The following is a description of a gene set: mouse primary BMDCs were stimulated with tlr ligands and gene expression changes were profiled on Affymetrix arrays Human Gene Set: GSE17721_12H_VS_24H_POLYIC_BMDC_DN species: Homo sapiens from publication Amit I, Garber M, Chevrier N, Leite AP, Donner Y, Eisenhaure T, Guttman M, Grenier JK, Li W, Zuk O, Schubert LA, Birditt B, Shay T, Goren A, Zhang X, Smith Z, Deering R, McDonald RC, Cabili M, Bernstein BE, Rinn JL, Meissner A, Root DE, Hacohen N, Regev A (PMID 19729616) Genes down-regulated in comparison of dendritic cells (DC) stimulated with poly(I:C) (TLR3 agonist) at 12 h versus those stimulated at 24 h., and this is the list of marker genes: SYNGR2, EIF3B, CD72, TP53INP1, C12orf57, NDUFC2, SS18L2, TMEM126A, POLR2A, OTULINL, SLC5A9, KLHDC4, PIP4P2, CD1D, TMEM161A, BRIX1, CYB5A, MS4A7, ENO3, B4GALT1, TRIM27, TCF12, ECD, PPT2, DNAJA3, CDCA3, NAA60, CTCF, CCT4, SLFN12, CSDE1, PEA15, ANAPC11, CLCC1, STK17B, GLI2, HINT3, HYOU1, CCT8 (NCBI Gene Id 9888), NCBP3, ITFG2, FOXK2, SNX15, RAC2, PTEN, WBP2, ENTREP3, ZMIZ2, NR2C1, NCBP1, SMC3, NSUN2, SDHD, DGKZ, TTLL1, UAP1L1, PTPN14, HEXIM1, DDX18, CSE1L, MAVS (NCBI Gene Id 78993), RCC1L, MORF4L1, PHF2, PLEKHJ1, C1D, ARMCX5, TRMT1, NUCB1, CCDC137, ABCF3, MYLIP, PTGR1, ARPC5L, MRPL57, SH3BGRL2, RNF138, PDE8A, FAM234B (NCBI Gene Id 57613), SLC40A1, RNASEK, TMEM131L, VPS26C (VPS26 endosomal protein sorting factor C), NCBP2, C3orf70, ITPR2 (inositol 1,4,5-trisphosphate receptor type 2), HDLBP, MPHOSPH10, OSGIN1, ICE1, PPFIBP2, GLIPR1L2, MS4A6A, GPANK1, PWP1, RAD51D, DDRGK1 (NCBI Gene Id 65992), TRPV2, RNF44, NOP16, TM4SF5, TRIT1, CSNK1G2, NUP210, PPCDC, RAB7A (RAB7A, member RAS oncogene family), SFXN3, IFT74, FASTK, TPRG1L, PTGS1, DSTYK, ARRB1, ACADM (acyl-CoA dehydrogenase medium chain), PITHD1, TSTD2, PCTP, MAP3K4, SLAIN2, PBDC1, SLC2A8 (NCBI Gene Id 29988), OAT, CSNK2A2, RNF103, HS1BP3, PRRX1 (NCBI Gene Id 5396), NLRX1, PHTF1 (NCBI Gene Id 10745, putative homeodomain transcription factor 1), CCDC107, GRK6, DARS1, SUPT20H, PSME3IP1, DTX3, EBPL, TMEM14C, SENP3 (SUMO specific peptidase 3), UBD, MPND, CXCR4, HIVEP1, FAM98A, PAFAH2, OSGIN2, DHRS7, MLLT10, STAT3, DYNLRB1, IL6ST, DOK3, GPNMB, ABCD1, APOBEC1, GHDC, SLC52A3, PUF60, INPP5D, EPPK1, CD300A, RPL9, CEP104, UTRN, POLR2E, RHOT2, MRTFA, MFSD6, BLTP3A, TRAP1, CLUH, TGM2, TEP1 (NCBI Gene Id 7011), TUBGCP5, SYK, MCM7, WFDC1 (WAP four-disulfide core domain 1), RNF167, CDK5RAP2, ZNF318, RIOK1, RASA3, SRSF11, MNT (NCBI Gene Id 4335, MAX network transcriptional repressor), ENTPD6, XRCC1, ZBTB20, TBC1D20, RNF20, GGH, MRPS33, IDH3B, FOXO1 (forkhead box O1), FYB1, HTATIP2, HSPA4, PARP1, CNR2, EIF4H, SERBP1, HMGA2, SYNJ2BP